The following is a description of a gene set: studied in species Homo sapiens The chemical reactions and pathways involving XMP, xanthosine monophosphate. Human Gene Set: GOBP_XMP_METABOLIC_PROCESS, and this is the list of marker genes: IMPDH1, PAICS, ADSL, PPAT, GART, IMPDH2, PFAS, ATIC